The following is a description of a gene set: Mouse Gene Set: MIR_6960_3P from publication Chen Y, Wang X (PMID 31504780) Genes predicted to be targets of miRBase v22 microRNA mmu_miR_6960_3p in miRDB v6.0 with MirTarget v4 prediction scores > 80 (high confidence targets). studied in species Mus musculus, and this is the list of marker genes: Cnih3, Rap2b, D5Ertd579e, Pcdh19, Tdrp, Ccer1, Zfp827, Herc6, Efnb3, Apaf1, Ube2g1, Lrp4, Odc1, Lypd1, Calml4, Fhip1b, Cnbp, Fbxo28 (F-box protein 28), Ptpn9, Ctnna2, Bivm, Ceacam12, Secisbp2l, Slc12a5, Atrnl1, Cdon, Kcns3, Nudt11 (NCBI Gene Id 58242), Scart2, Mtmr6, Ubr5, Srek1, Fbxw5, Crb2